Given this list of marker genes KLHL7, SLC4A10, HYCC1, DMRT3, MYO3B (NCBI Gene Id 140469), DNAJC21, SLTM, SOBP, BCL2L2, TBC1D8B, PUM2, ING3, WAPL, CBX4, SRSF5, RBM3, NREP, PIK3CD, SORCS1, BRINP3, MLEC, SMC1A (NCBI Gene Id 8243), ZC3H12B, H3-3B, CCDC9B, HMGN1, JPH4, ARGLU1, ADGRB3, FHL1, TMEM117, ANK2, KCNIP2, SLC25A3, IL1RAPL1, TBR1, TJAP1, ZFP36L1, ARL2BP, CD9 (NCBI Gene Id 928), SLC25A33, USP8, KLF12, EGLN3, ANTXR1, CELF2, DTNA, SCRT1, FLT3, GTF3C2, CS, CREBRF, CBX8, TAB1, HNRNPR, SS18, ZKSCAN2, FBRS, here is a description of the gene set: Genes having at least one occurence of the motif CTCTAGA in their 3' untranslated region. The motif represents putative target (that is, seed match) of human mature miRNAs hsa-miR-526c, hsa-miR-518f* and hsa-miR-526a (v7.1 miRBase). studied in species Homo sapiens Human Gene Set: CTCTAGA_MIR526C_MIR518F_MIR526A